Given this list of marker genes Tcf21, Foxf1, Bmpr2, Errfi1, Bmp4 (bone morphogenetic protein 4), Id1, Vegfa, Bmp2, Igf1, Ift88, Lif, Stra6, here is a description of the gene set: Mouse Gene Set: GOBP_LUNG_VASCULATURE_DEVELOPMENT The biological process whose specific outcome is the progression of a lung vasculature from an initial condition to its mature state. This process begins with the formation of the lung vasculature and ends with the mature structure. The lung vasculature is composed of the tubule structures that carry blood or lymph in the lungs. species: Mus musculus